Given this list of marker genes HEY2, ACTA1, ACVR1, HEYL, WNT5A, APLNR, FOXC2, MSX1, TWIST1, TBX3, DCHS1, TMEM100, MYC, MDM2, SMAD3, BMP7, SOX9, CPLANE2, NCKAP1, SNAI1, BMP4, NOTCH1, GATA5, ROBO2, APC, BMPR1A, ACTA2, ROBO1, MDM4, FOXF1 (NCBI Gene Id 2294), TGFB2, WNT3A, TGFBR2, LEF1, OSR1, TBX2, TGFB3, NOS3, ACTG2, TGFBR1, NOG, TGFB1, FGFR1, ISL1, WNT11, SNAI2, MSX2, BMP2, FOXC1, BMP5, ACVRL1, FGF8, EXOC4, ENG, TBX20, HEY1, ACTC1, ADAMTS5, TAF10, RBPJ, SMAD4, SMAD2, here is a description of the gene set: Human Gene Set: GOBP_MESENCHYME_MORPHOGENESIS studied in species Homo sapiens The process in which the anatomical structures of a mesenchymal tissue are generated and organized. A mesenchymal tissue is made up of loosely packed stellate cells.